The following is a description of a gene set: species: Homo sapiens Human Gene Set: REACTOME_RAS_PROCESSING RAS processing, and this is the list of marker genes: ABHD17C, GOLGA7, FNTB, PRKG2, UBC, ICMT, FNTA, UBB (ubiquitin B), USP17L2, RCE1, NRAS, UBA52, BCL2L1, ZDHHC9, ABHD17A, PDE6D, CALM1, PRKCQ, LYPLA1, ARL2, KRAS, HRAS, ABHD17B, RPS27A